The following is a description of a gene set: studied in species Homo sapiens Increase in width of the nasal tip. Broad nasal tip Human Gene Set: HP_BROAD_NASAL_TIP, and this is the list of marker genes: SATB2, IDUA, PHF21A, FBXO28, KIF7, HRAS, TOPORS, RNU4-2, PHIP, TPR, ZSWIM6, PTPRF, ZFX, TMEM231, WASHC4, SOX4, RHOBTB2, KAT6A, TBL1XR1, AHDC1, CDC42BPB, EBF3, MYMK, TBX2, KCNK9, RYR1, GPAA1, NIPBL, SMARCA4, HDAC4, KDM5A, NSD1, NRAS, SETD2, PRMT7, DPF2, ARSL, PUF60, DYRK1A, TCTN3, ADNP, IGF1R, ARID2, HS2ST1, ALX3 (ALX homeobox 3), ATP6V1E1, RAB3GAP2, KNSTRN, BPTF, TWIST1, TLK2, ACTB, CDH11, SNRPN, SETBP1, ATP6V1A, SMARCAL1, EXTL3, SOX11, PHF8, QRICH1, LAS1L, NXN, CCNK, LTBP1, SMARCB1, SMARCD1, PIK3CD, RAB3GAP1, TFAP2B, CDK10, TFAP2A, KPTN, HDAC8, PIGO, KDM6A, SMARCC2, KIAA0753, ATP6V1B2, H4C5, ATP6V0A2, ASXL3, SMG9, ZBTB20, CTCF, GATAD2B, CTNNB1, EXOSC2, PIGQ, ADAMTS18, SET, NACC1, TMEM216, ASXL2, COG6 (component of oligomeric golgi complex 6), GLB1, BCOR, KIF11, DOCK7, WDR26, AIFM1, FOXP1, PORCN, FREM1, SUPT16H, WAC, MAP3K7, SRCAP, ABCC9, FBXO11, EXT2 (NCBI Gene Id 2132), TBC1D24, ALX4, MAB21L1, MLXIPL, KMT2A, KDM3B, GLI2, XRCC4 (X-ray repair cross complementing 4), PGAP3, KCNH1, CASK, FAM149B1, SH3PXD2B, KCNN3, APC, YY1 (NCBI Gene Id 7528), H4C3, CCNQ, OFD1, SMC3, PRKAR1B, AGL, PRKAR1A, ZMYM2, PURA, POGZ, POC1A, RARB, LRP2, HUWE1, NEK1, SIX2, ARID1A, RNF135, METTL5, HNRNPK, FLNB, MCTP2, ARID1B, SMARCE1, PPP2CA, TAF1, RPS6KA3, EIF2S3, TOE1, ELN, PDE6D, DPYD, RFX7, PIGV, PGAP2, CAPRIN1, CPLANE1